Given this list of marker genes Chchd3, Naa50, Edem1, Pigg, Mc3r, Pxn, Plekha7, Vash1 (NCBI Gene Id 263410), Sec22c, Cdk5r1, G3bp2, Nfya, Nufip2, Rogdi, Mrps24, Gm14461, Grik2, Foxo4, Csnk2a1, Chrdl1, Gab1, Sspn, Ywhaz, Msi2, Llph, Capn11, Gabarap, Fbxo10, Adora1 (adenosine A1 receptor), Cox7b, Rmdn3, Synm, Kpna6 (NCBI Gene Id 16650), Arpc5l, Prx (periaxin), Gm13275, Stk26, Dynll2, Rgn, Baz2a, Rgs16, Adcyap1r1, Brd8, Arl4c (NCBI Gene Id 320982), Thoc1 (THO complex 1), Ntng1, Sox21, Zfp711, Nsd2, Txnrd1, Ntaq1, Usp49, Mboat2, Nlrp12, here is a description of the gene set: from publication Chen Y, Wang X (PMID 31504780) Mouse Gene Set: MIR_1968_3P Genes predicted to be targets of miRBase v22 microRNA mmu_miR_1968_3p in miRDB v6.0 with MirTarget v4 prediction scores > 80 (high confidence targets). studied in species Mus musculus